Given this list of marker genes CD72, GLG1, ACYP1, HSBP1, METTL3, RAB8B, TSHR, LHX3, OMD, MAFG, DNAJC8 (NCBI Gene Id 22826), CDC5L, UQCC3, KLKB1, TXNDC17, KLF4, RNF14 (ring finger protein 14, NCBI Gene Id 9604), UQCRHL, ARPC3, NIP7, RPS6KA2, PPM1A, IL17RA, PTP4A2, EIF2AK4, CD48, CD53, CYTH3, CNGA2, BCL2L11, GAST, FGL2, LSP1, CDADC1, SPIN1, FSHB, IL3RA, LGALS1, KDM3A, RAP2A, ANXA8, ITIH5, EVX2, ZFP36L2, USP38, HIPK1, LAMP1, PPIC, PLA2G5, IRF9, MAT1A, FMOD, PERP, PTK2, HELB, KRT12, TGIF1 (NCBI Gene Id 91941), SLC6A2, BTF3, NTMT1, SCEL, PON2, DNAJA1, IL36RN, SSTR2, FBXW2, B4GALT6, MPG, IFIT1B, TMOD3, DSTN, WDR43 (WD repeat domain 43), COMT, SNAI1, DSPP, CCL4, SLFN12, MYCL, ESD, RELL1, REPS1, MAN1A1, MYO1B, FGF9, SPCS2, FRAT1, CPT1A, GLI3, SQSTM1, SERTAD1, GDF15, RETREG1, RASGRF2, TNNI2, EIF4EBP1, ITGAE, RRH, CYTIP (cytohesin 1 interacting protein), NIPSNAP2, COL10A1, GLRX3 (glutaredoxin 3), RNF123 (NCBI Gene Id 63891), ELOVL3, NKIRAS1, TCP11, SEM1, A2M, CRIPT, PTPRO, SERPINI1, SCG2, MDFI, FUS, PTGIS, DYNLT3, CACNA2D1, SUPT4H1, RPL6, RHOH, RER1, RELB, EIF3J, ASNSD1, POLD4, QNG1, MCEE, SUDS3, FOXD4L1, ISG20, EDF1, DDX19A, IL12B, ELL, ZSCAN12, VAMP5, PNCK, KCTD12, CD5L, AQP4, TCEA1, ATF6, ISG15, ASPSCR1, ZFP92, KRT20, SERPINB9, RCN1, NUFIP1, ZC3H15 (zinc finger CCCH-type containing 15), APBB1IP, PRG3, TNFSF10 (NCBI Gene Id 8743), ERBB4, LAMTOR4, GBP2, TIMM23, SORD (NCBI Gene Id 6652), NAA38, CAPN7, NRGN, ZNF362, CRYGB, USE1 (unconventional SNARE in the ER 1), MRPL16, PJA1, PTRH2, PLS3, CXorf38, RTN1, NPY5R, MMP2, MST1, RP9, SLC23A1, SCARB2, PSMD9, TAL2, CLIP4, CPNE6, PTGES, CDC16, CHP1, HINT2, CD7, ZNF865, NDUFB5, RIT1 (Ras like without CAAX 1), FAM3D, STMP1, PTPRB, GBA1, ABCD2, RNF19A, DHRS7, MFF, POU1F1, SYT17, GM2A (ganglioside GM2 activator), TRPC5, RAB6A, here is a description of the gene set: from publication Niederberger N, Buehler LK, Ampudia J, Gascoigne NR (PMID 15661827) Human Gene Set: GSE1448_CTRL_VS_ANTI_VALPHA2_DP_THYMOCYTE_DN Genes down-regulated in comparison of control CD4 CD8 thymocytes versus those after stimulation with anti-Valpha2 antibodies. Comparison of gene expression changes in CD4+CD8+ thymocytes following engagement of TCR with anti-Valpha or Vbeta antibodies studied in species Homo sapiens